The following is a description of a gene set: The ability of growth factors to protect from apoptosis is primarily due to the activation of the AKT survival pathway. P-I-3-kinase dependent activation of PDK leads to the activation of AKT which in turn affects the activity or expression of pro-apoptotic factors, which contribute to protection from apoptosis. AKT activation also blocks the activity of GSK-3b which could lead to additional antiapoptotic signals. Reactome Pathway: PI-3K cascade:FGFR4 studied in species Homo sapiens part of: Downstream signaling of activated FGFR4, and this is the list of marker genes: FGF4, PTPN11, GAB1, FGF1, FGF6, FGF16, FGF17, FGF9, FGF8, GRB2, KLB, FGF20, PIK3CA, FGFR4, FRS2, FGF23, FGF19, FGF2, FGF18, PIK3R1